Given this list of marker genes E2f2, Rnf208, Pcdh7, Abcc5, Dock3, Sh2b3, Trim71, Epha4, Zfp518a, Ago4, Fat4, Dffa, Casp2 (caspase 2), Ppp2ca, Dnal4, Atl2, Sec14l2, Shtn1 (NCBI Gene Id 71653), Sfmbt1, Unc5c, Hdx, Ubr7, Wdr1, Syvn1, Lyz2, Arcn1, Bhlha15, Nrg3, Ugt1a2, Tpm4, Brwd1, St8sia6, Asxl3, Golga5, Tafazzin, Arid3a, Zbtb34, Itch, Rasgef1a, Wdr77, Scn5a, Dipk2a, Zdhhc7, Smap2, Cbll1, Stard13, Trpm2, Grb10, Sanbr, Dnajc14, Pcmtd2, Cdcp3, Sash1, Zdhhc9, Prkra, Tmprss13, Kdm7a, Peak1, Fgfr2, Brwd3, Baat, Gls, Trib2, Repin1, Zbtb37, Apba1, Cgn, Sun1, Coro2b, Gcnt1, Xndc1, 0610040J01Rik, Pga5, Rfx5, Cyyr1, Dus1l (NCBI Gene Id 97781), Elavl4, Edn1, Rbak, Rassf3, Pkp4, Ccbe1, Lhx8, Apc (NCBI Gene Id 11789), Dcp1a, Etv3, Zzz3, Atp2b3, Ppp4r3a, Sel1l, Rbm24, Lce1d, Ugt1a6a, Grhl1, Gjc1, Tppp, Zfp281, Enpep, Syde2, Pcsk7, Lactb, Sstr3, Usp38, Ccnjl, Ugt1a7c, Ece1, Eaf1, Qki, St6galnac6, Atxn7, Adam9, Slc39a9, Snx18, Hinfp (NCBI Gene Id 244832), Ppm1h, Ankib1, Zfp62, Crem, Neu1, Kansl1l, Atxn3, Yod1, Cbfb, Rmnd5a (NCBI Gene Id 79046), Tspan12, Zfp697, Irf4, Esrrg, Cdh5, Stxbp5l, Bpnt2, Srsf6, Gpatch8, Ralgps2, Dazap2, Foxq1, Gpr141, Plekha8, Gxylt1, Zfp12, Unc93a, Gucy2f, Unc5d, Nedd9 (neural precursor cell expressed, developmentally down-regulated gene 9), Vps37b, Fam234b (family with sequence similarity 234, member B), Crb2, Zbtb4, Cdk19, Zfp148, Ccna2, Tmem135, Phactr3, Bcl2l2, Slc35a4, Vps4b, Vdr, Sbno1, Map3k1 (mitogen-activated protein kinase kinase kinase 1), Mgat5, Acer3, Triap1, Pi4k2b, Nipal4, Ugt1a9, Gucy1a2, Ino80d, Ugt1a5 (NCBI Gene Id 394433), Lfng, Tmem132e, Tox, Cecr2, Phf20, Slco3a1, Tet2, Ugt1a10, Pde1c, Rasal2, Ugt1a1, Abtb1, Kif1b, Pdcd4, Arid3b, Slc24a2, Tmem120b, here is a description of the gene set: from publication Chen Y, Wang X (PMID 31504780) species: Mus musculus Genes predicted to be targets of miRBase v22 microRNA mmu_miR_670_5p in miRDB v6.0 with MirTarget v4 prediction scores > 80 (high confidence targets). Mouse Gene Set: MIR_670_5P